The following is a description of a gene set: species: Mus musculus Mouse Gene Set: GOBP_POSITIVE_REGULATION_OF_GONADOTROPIN_SECRETION Any process that activates or increases the frequency, rate or extent of the regulated release of a gonadotropin., and this is the list of marker genes: Foxl2, Inhbb, Kiss1, Smad4, Acvr2a, Lep